Given this list of marker genes Clcn3, Atp1b2, Nphp4, Usp45, Rho, Tub, Cdhr1, Adgrv1, Esrrb, Clrn1, Bbs10, Ercc6, Nxnl1 (nucleoredoxin-like 1), Tulp1, Bbs1 (Bardet-Biedl syndrome 1), Bbs12, Ush2a, Cep290, Ush1c, Cln8, Lca5, Pcdh15, Mkks, Cdh23, Crb1, Dram2, Pde6a, Abca4, Ush1g, Crocc, Rp1l1, Crb2, Cngb1, Arap1, Slc2a1, Nxnl2, Rp1, Map1a, Nphp3, Iqcb1, Spata7, Cib2, Bsg, Bbs2 (Bardet-Biedl syndrome 2), Bbs4, Mak, Prom1, here is a description of the gene set: studied in species Mus musculus Mouse Gene Set: GOBP_PHOTORECEPTOR_CELL_MAINTENANCE Any process preventing the degeneration of the photoreceptor, a specialized cell type that is sensitive to light.